Given this list of marker genes PDK4, CRABP1, DLAT, DHRS9, ADH1C, CYP26A1, RARG, ALDH1A1, DHRS4, RDH11, PDK1, RDH14, ALDH8A1, ADH1A, CYP26C1, RXRB, RXRA (NCBI Gene Id 6256), RDH16, DHRS3, PDHX, PDHA2, PDK2, CYP26B1, DLD, PDHA1 (pyruvate dehydrogenase E1 subunit alpha 1), RDH5, RARB, ALDH1A2, RARA, ADH4, SDR16C5, FABP5, RDH13, PDK3 (NCBI Gene Id 5165), ALDH1A3, CRABP2, AKR1C3, RXRG, PPARD, PDHB, RDH10, here is a description of the gene set: Vitamin A (retinol) can be metabolised into active retinoid metabolites that function either as a chromophore in vision or in regulating gene expression transcriptionally and post-transcriptionally. Genes regulated by retinoids are essential for reproduction, embryonic development, growth, and multiple processes in the adult, including energy balance, neurogenesis, and the immune response. The retinoid used as a cofactor in the visual cycle is 11-cis-retinal (11cRAL). The non-visual cycle effects of retinol are mediated by retinoic acid (RA), generated by two-step conversion from retinol. All-trans-retinoic acid (atRA) is the major activated metabolite of retinol. An isomer, 9-cis-retinoic acid (9cRA) has biological activity, but has not been detected in vivo, except in the pancreas. An alternative route involves BCO1 cleavage of carotenoids into retinal, which is then reduced into retinol in the intestine. The two isomers of RA serve as ligands for retinoic acid receptors (RAR) that regulate gene expression.. RA is catabolised to oxidised metabolites such as 4-hydroxy-, 18-hydroxy- or 4-oxo-RA by CYP family enzymes, these metabolites then becoming substrates for Phase II conjugation enzymes (Ross & Zolfaghari 2011). species: Homo sapiens Reactome Pathway: Signaling by Retinoic Acid part of: Signaling by Nuclear Receptors